Given this list of marker genes CERS6, SGMS2, DEGS2, SPTLC1, ASAH1, CERS2, SPTLC2, PLPP1, SGPL1, PLPP2, SGPP1, SMPD1, PLPP3, KDSR, SPHK1, CERS1, CERK, CERS5, DEGS1, CERS4, SGMS1, SGPP2 (sphingosine-1-phosphate phosphatase 2), CERS3, UGCG, UGT8, SPHK2 (NCBI Gene Id 56848), here is a description of the gene set: Sphingolipid metabolism: integrated pathway Human Gene Set: WP_SPHINGOLIPID_METABOLISM_INTEGRATED_PATHWAY species: Homo sapiens